Given this list of marker genes MT1M, MT1B, MTF1, MT1F, MT3 (NCBI Gene Id 4504), MT1G, SNCB, MT4, MT2A, MT1A, CSRP1, MT1E, MT1X, MT1H, here is a description of the gene set: Human Gene Set: REACTOME_RESPONSE_TO_METAL_IONS Response to metal ions species: Homo sapiens